Given this list of marker genes TYMS, MTHFD1, SLC46A1, SLC19A1, GART, FOLR1, ATIC, DHFR, SHMT1, MTHFR, FTCD, QDPR, SHMT2, MTHFS, MTHFD2L, MTHFD2 (methylenetetrahydrofolate dehydrogenase (NADP+ dependent) 2, methenyltetrahydrofolate cyclohydrolase), MTR, ALDH1L1, ALDH1L2, here is a description of the gene set: Human Gene Set: WP_DISORDERS_OF_FOLATE_METABOLISM_AND_TRANSPORT Disorders of folate metabolism and transport studied in species Homo sapiens